Given this list of marker genes C1orf116 (chromosome 1 open reading frame 116), CSF2, TMPRSS11E, SOX9, GPRC5A, TGFA, VGLL1, SCEL, DSC2, HS3ST2, P2RY2, ATP12A, ARHGAP25, MFAP5 (microfibril associated protein 5), MTARC1 (mitochondrial amidoxime reducing component 1), HBEGF, SPRR2D, DUSP6, DEPP1, ST6GALNAC5, KRT15, IL36G, IL1R2, IVL, TP63, KLK11, CEACAM6, S100A7, EHF, KRT13, PTGS2, PI3, FST, MYO5C, KLK10, SPAG1, KRT8, ADGRE2, ANO1, LCN2, CXCL2, CSF3 (NCBI Gene Id 170794), IL1B, MMP10, SERPINB2, EDN1, SERPINB13, CXCL3, PTHLH, CXCL8, CXCL1, NAV3, CYB5R2, CWH43, ARL4C, EPN3, KLK7, CRCT1, SERPINB1, here is a description of the gene set: species: Homo sapiens from publication Onder TT, Gupta PB, Mani SA, Yang J, Lander ES, Weinberg RA (PMID 18483246) Loss of the epithelial adhesion molecule E-cadherin is thought to enable metastasis by disrupting intercellular contacts-an early step in metastatic dissemination. To further investigate the molecular basis of this notion, we use two methods to inhibit E-cadherin function that distinguish between E-cadherin's cell-cell adhesion and intracellular signaling functions. Whereas the disruption of cell-cell contacts alone does not enable metastasis, the loss of E-cadherin protein does, through induction of an epithelial-to-mesenchymal transition, invasiveness, and anoikis resistance. We find the E-cadherin binding partner beta-catenin to be necessary, but not sufficient, for induction of these phenotypes. In addition, gene expression analysis shows that E-cadherin loss results in the induction of multiple transcription factors, at least one of which, Twist, is necessary for E-cadherin loss-induced metastasis. These findings indicate that E-cadherin loss in tumors contributes to metastatic dissemination by inducing wide-ranging transcriptional and functional changes. Genes down-regulated in HMLE cells (immortalized nontransformed mammary epithelial) cells after loss of function of E-cadhedrin (CDH1), which was achieved either by RNAi knockdown or by expression of a dominan-negative form of CDH1. Human Gene Set: ONDER_CDH1_TARGETS_3_DN